The following is a description of a gene set: Acral overgrowth species: Homo sapiens Human Gene Set: HP_ACRAL_OVERGROWTH Excessive growth of hands and feet (predominantly due to soft tissue swelling). Typical manifestations include shoe size increase, foot enlargement, glove tightness, and hand enlargement., and this is the list of marker genes: CAVIN1, AIP, PIK3CA, GPR101, GNAS, PRKAR1A, PLAAT3